The following is a description of a gene set: Genes down-regulated in prefrontal cortex (PFC) of mice carrying a hemizygotic microdeletion in the 22q11.2 region. from publication Stark KL, Xu B, Bagchi A, Lai WS, Liu H, Hsu R, Wan X, Pavlidis P, Mills AA, Karayiorgou M, Gogos JA (PMID 18469815) Individuals with 22q11.2 microdeletions show behavioral and cognitive deficits and are at high risk of developing schizophrenia. We analyzed an engineered mouse strain carrying a chromosomal deficiency spanning a segment syntenic to the human 22q11.2 locus. We uncovered a previously unknown alteration in the biogenesis of microRNAs (miRNAs) and identified a subset of brain miRNAs affected by the microdeletion. We provide evidence that the abnormal miRNA biogenesis emerges because of haploinsufficiency of the Dgcr8 gene, which encodes an RNA-binding moiety of the 'microprocessor' complex and contributes to the behavioral and neuronal deficits associated with the 22q11.2 microdeletion. Mouse Gene Set: STARK_PREFRONTAL_CORTEX_22Q11_DELETION_DN species: Mus musculus, and this is the list of marker genes: Sac3d1, Hibch, Tcp1, Phc2, Sdhaf4, Hmox2, Strbp, Tango2, Mrps17, Smim29, Timm8b, Atp5mf, Mrpl40, Mrpl51, Mrps23, Mpped2, Zdhhc16, Sap18, Tmem165, Sec11c, Naa38, Atp6v1d, Bok (NCBI Gene Id 98569), Tubg1, Nipsnap1, Cdk5 (NCBI Gene Id 12568), St13, Prps2, Brwd1, Cbr1, Idh3a, Rrp7a, Fkbp2, Gpr83, Prodh, Rundc3a (RUN domain containing 3A), Cox7a2, Hagh, Cbx3, Mtln, Cops6, Akr1b1, Psmc1, Sumo1 (small ubiquitin-like modifier 1), Tmem42, Ssr4, Ppm1l (protein phosphatase 1 (formerly 2C)-like), Cops3, Acat2, Slc25a1, Atp5f1c, Fn3k, Rab5if, Akr1a1, Dennd5b, Fkbp3, Srp9, Tma7 (translational machinery associated 7), Timm17a, Phip, Sar1b, Eloc, Mrpl11, Mettl8, Ufc1, Trmt112, Smyd2, Rpl36al, Arhgap15 (NCBI Gene Id 76117), Abt1, Bbln, Cnpy2, Scnm1, Atp5pf, Mgst3, Uqcrfs1, Adcy8, Ifngr2, Ppil3, Slc25a39, B4galt3, 6330403L08Rik (RIKEN cDNA 6330403L08 gene), Atox1, Cisd1, Uqcrc2, Inip, Stau1, Romo1, Impact, Usp1, Naxe, Nsg2, ENSMUSG00000124632, Ndufs1, Bnip1, Tmeff2, Prdx1, Ndufs4 (NADH:ubiquinone oxidoreductase core subunit S4), Pet100, Txndc17, Tpd52, Rpl34 (NCBI Gene Id 68436), Eri3, Eif6, Dgcr6, Chmp4b, C1galt1c1, Hcfc1r1, Ist1, Scn2b (NCBI Gene Id 72821), 1110059E24Rik, Sra1, Bcap31, Nr1h2, Wdr17, Car15, Snora74a, Smarcb1, Golga2, Fabp3-ps1, Ndufb2, Prdx3, 1810037I17Rik, Atp5if1, Gabrd, Hs3st4, Ndufa11, Hspbp1, Dipk1b, Bscl2, Gde1, Tomm34, Uqcc2, Nudt21, Fh1, Yaf2, Cwf19l1, Eif4e, Ogfrl1 (opioid growth factor receptor-like 1), Lrrc4c, Pgrmc2, Asph, Ubac1, Ess2, Polr2j, Emp2, Elp5, Nsd2, U2af1l4, Pop7, Iftap, Sema3a, Pomp, Trappc2l, Tesk1, Eif2b4, Ndufv2, Cldn5, Eif4g2, Gskip, Psmb4, Sec22b, Plcb4, Carm1, Cct5, Tomm40l, Eif2s1, Tbc1d9b, Idh3g, Ank3, Timm23, Atp5po, Rps17, Tst, Dek, Taf9, Ppp1ca, Mthfd2l, Plekho1, Tshz3 (NCBI Gene Id 338507), Dtnbp1, Nfix, Pfdn6, Txn1, Abhd11, Ndufb4, Ntan1, Pfdn5, Txnrd2, Ppp1r9a, Znhit1, Rheb, Ndufs6, Rmnd5b, Evi2a, Psmg2 (NCBI Gene Id 75651), Pde6d, Tspan31, Pkib, Uqcc5, Trmt10b, Med28, Wtap, Ugp2, Coa3, Rpl26, Tpd52l1, Vps35, Cuedc2, C1qbp, Mrpl57, Krtcap2, Tmem126a, Dmac1, Nenf, Nudc, Mrps22, Bud31, Mpc2, C9orf72, Dctn6, Fdps, Spsb3, Tmem256, Cyb561a3, Psma5, Srr, Rars1, Eif3l, Cfdp1, Mrpl3, Fam136a, Zfp868, Zdhhc8, Hspe1, Aimp1, Ark2c, Gm57857, Vdac2, Snhg10, Tceal8, Nme1, Bcap29, Mblac2, Ttc33, Adh5, Nprl2, Get3, Elob, Gls2, Fnta, Zfp511, Creb3, Smu1, Pdcd5, Nono, Tmx2, Chn2, Mrps18a, Trbc1, Ndufs3, Fndc4, Wdr82, Smim26, Gng13, Omg, Cox14, Pcdh11x, Elmo1, Epm2aip1, Slc25a46, Lrpap1, Cox7c, Vps4a, Mettl26, Commd8, Bckdhb, Resp18, Ss18l2, Pura, 2310011J03Rik, Nifk (NCBI Gene Id 98469), Slirp, Eif3h, Mapk10, Nipa1, Ipo9, Ttll7, Ufsp2, Idh1, Mrpl42, Nop10, Hira, Cystm1, Rpl36a, Rpl8, Mis18a, Cpsf3, Fmc1, Psmd14, Haghl, Ndufa7, Cryzl1, Uqcr10, Coprs, Snapc2, Pfdn2, Arhgap35, Txnl4b, Dynlrb1, Kdm1a (NCBI Gene Id 99982), Nme2, Hpf1, Polr1d, Pak1, Nup88, Hapln4, Rab26, Praf2, Rpl5, Pdgfa, Polr1c, B4gat1, Comt (NCBI Gene Id 319399), Mrpl28, Naca, Jkamp, Tmsb10, Slitrk4, Ndufa12, Mea1, Nars1, Emc2, Rpl18, Vps13a, Baz1b, Osbpl1a, Pip4p1, Snrnp27, Gtf3a, Psma3, Tmem44, Gins4, Scand1, Eif3f, Kpna1, Denr, Myl4 (NCBI Gene Id 17896), Incenp, Ddrgk1, Cyc1, Bccip, Stip1, Rtn4r, Gpi1, Scg5, Ociad2, Rnf34, Atp5f1e, Mrpl15, Zfp560, Gp1bb, Smim7, Rit1, Lamtor2, Ubl4a, Prxl2b, Micos13, Vdac3, Ndufs8, Clns1a, Tmem59l, Mpi, Hibadh, Psma2, Zswim7, Nfu1, Carf, Alad (aminolevulinate, delta-, dehydratase), Mcts1, Samd5 (NCBI Gene Id 320825), Gpatch8, Trir, Trmt2a, Czib, Pdxdc1, Ndufaf3, Atp6ap1, Leprotl1, Psmb6, Ranbp1, Oat, Hspa4l, Coro7, Ddx56, Gcsh, Mvd, Sirt2, Slc27a4, Sec63, Ccdc127, Rgs20, Cct3, Arvcf, Snx32, Mdh2, Glg1, Lgi2, Rab4b, Ppp2r5c, Eeig1 (NCBI Gene Id 98952), Cycs, Nagk, S100a6, Pdcd6, Elof1, Rad23a, Particl, Wdr45, Cep19, Cndp2, Fam120aos, Ndufb11, Hypk, H2az1, Rpl4, Tceal9, Dgcr8, Rpl15, Dcaf11, Dpm2, Atp6v1e1, Mrpl41 (NCBI Gene Id 20007), Acot13, Tra2b, Prdx2, Enoph1, Arpc5l, Dnajc15, Usp34, Chchd1, Sec62 (SEC62 homolog, preprotein translocation), Sars1, Tmem208, Lysmd4, Mkks, Dynll1, Aldoa, Cct2, Ogfod3, Fig4, 2510002D24Rik, Rabl6, Trim59, Slc25a20, Psmb3, Psmc4, Mrps12, Stmn2, Snx7, Blvra, Eif1, Tomm20, Ndufa8, Ndufa9, Ndufs7, Higd2a, Snx16, Cacybp, Psmc3, Rtraf (NCBI Gene Id 68045), 6330403K07Rik, Nmt2, Tle4, Zftraf1, Atp5mg, Rad23b, Arap2, Sdhaf3, Sec61b, Pdhb, Hsd17b7, Actr10, Kpna2, Kantr, Mzt2, Arhgap20, Ahsa1, Usp39, Tpi1, Ufd1, Kxd1, Eif3k, Mrpl55, H2ac25, Ndufb10, Sgtb, C1qtnf4, Snrpc, Dgcr2, Stmn3, Tln1, Cox5b, Guk1, Nudt19, Thoc7, Selenoh, Atp5pd, Rpl22l1, Tm7sf2, Snrpd2, Dap3, Acsl1, Slc25a5, Immp1l, Mrps28, Mrpl17, Sik3, Cisd3, Ppt1, Gdap1, Ap2m1, Atp5me, Alcam, Fam162a, Tmem147 (NCBI Gene Id 69804), Lamtor1, Gm13205, Ndufa2, Coq4, Micos10, Mrps11, Mllt11, Sbds, Prelid1, Uqcr11